The following is a description of a gene set: Lymphatic vessels are essential for fluid homeostasis, immune surveillance and fat adsorption, and also serve as a major route for tumor metastasis in many types of cancer. We found that isolated human primary lymphatic and blood vascular endothelial cells (LECs and BECs, respectively) show interesting differences in gene expression relevant for their distinct functions in vivo. Although these phenotypes are stable in vitro and in vivo, overexpression of the homeobox transcription factor Prox-1 in the BECs was capable of inducing LEC-specific gene transcription in the BECs, and, surprisingly, Prox-1 suppressed the expression of approximately 40% of the BEC-specific genes. Prox-1 did not have global effects on the expression of LEC-specific genes in other cell types, except that it up-regulated cyclin E1 and E2 mRNAs and activated the cyclin e promoter in various cell types. These data suggest that Prox-1 acts as a cell proliferation inducer and a fate determination factor for the LECs. Furthermore, the data provide insights into the phenotypic diversity of endothelial cells and into the possibility of transcriptional reprogramming of differentiated endothelial cells. from publication Petrova TV, Mäkinen T, Mäkelä TP, Saarela J, Virtanen I, Ferrell RE, Finegold DN, Kerjaschki D, Ylä-Herttuala S, Alitalo K (PMID 12198161) species: Homo sapiens Human Gene Set: PETROVA_ENDOTHELIUM_LYMPHATIC_VS_BLOOD_DN Genes down-regulated in BEC (blood endothelial cells) compared to LEC (lymphatic endothelial cells)., and this is the list of marker genes: RNASE1, LTBP2, NMT2, ANPEP, LYL1, GBP2, ISG15, CHST1, RRAS, GADD45A, RHOB, MT1B, TGFBI, CXCL1, IL4R, DKK1, CAP2, ADGRG6, TCN2, SELP, MT1H, TP53I3, ARL6IP5, ADGRL2, ITGAV, SLC3A2, IER3, UAP1, EPS8, VEGFC, RGS10, ARHGAP22, AXL, CXCL8, IL32, CDH2, HMOX1, ATP1B1, TAGLN, ANXA3, IFI27, FLT1, SRGN, MT1F, ANXA6, ARHGDIB, RCN1, MT1E, PLA2G4A, ZBTB18, TXNRD2, NUAK1, COL1A2, CD59, CLU, MMP1, ARL4C, PLTP, NNMT, NISCH, COL6A1, SLC1A1, IL6, ICAM2, TPM2 (NCBI Gene Id 7169), GLCE, EXT1, TFEC, PLOD2, UPP1, CXCR4, PGF, VCAN, TACSTD2, SRPX2, SELE, CEP170B, ITM2A, LAMA5, PKIA, SLC6A8, PROCR, PLOD1, PRKACB, LY75, MBOAT7, IGF2BP3, FBXL2, UCHL1, KRT7, AHNAK2, BASP1, FAM107A, MMP14, BMP6, RGS4, LAMP2, NR2F2, BGN, CD44, LOXL2, NRCAM, SLC7A7, BTG2, NPTX1, SERPINE1, PFKM, ICAM1, CDC42EP3, PLAU, EFEMP1, FHL2, SGSH, MVP, MT1A, TPM1, CCRL2, COL8A1, KLHL21, FAP, EIF2B2, SMURF2 (NCBI Gene Id 64750), PDLIM4, CTSC, APBB2, JUN, CCL2, ITGB5, PFN2, ACTA2, TGM2, CYFIP2, MT1X, CDKN1A, SORD, CLDN7, AGRN, LPXN, EMP3, LDHB, SLC38A6, MECOM, TANK, ENO2, PCDH1, LAMC2, TNFRSF21, SRPX, ECE1, GSDME, CAPG, ALDH2, ITGA5, PRNP (NCBI Gene Id 96713), TRIM22, TRAM2, MT3, STAT6, RAC2, MAPKAPK3, SMAD3, MLLT11